Given this list of marker genes Mks1, Tmem107, Tmem231, Tmem17, Tmem216, Cc2d2a, Tmem67, Cep290, B9d2, B9d1, Ahi1, Kctd10, Tctn2, Tctn1, here is a description of the gene set: studied in species Mus musculus A protein complex that is located at the ciliary transition zone and consists of several proteins some of which are membrane bound. Acts as an organiser of transition zone inner structure, specifically the Y-shaped links, in conjunction with the NPHP complex. The MKS complex also acts as part of the selective barrier that prevents diffusion of proteins between the ciliary cytoplasm and cellular cytoplasm as well as between the ciliary membrane and plasma membrane. Mouse Gene Set: GOCC_MKS_COMPLEX